The following is a description of a gene set: Human Gene Set: GSE15215_CD2_POS_VS_NEG_PDC_UP Plasmacytoid dendritic cells (pDCs) are key regulators of anti-viral immunity. They rapidly secrete IFN-alpha and cross-present viral antigens thereby launching adaptive immunity. Here we show that activated human pDCs inhibit replication of cancer cells, and kill them in a contact dependent fashion. Expression of CD2 distinguishes two pDC subsets with distinct phenotype and function. Both subsets secrete IFN-alpha and express Granzyme B and TRAIL. CD2high pDCs uniquely express lysozyme and can be found in tonsils and in tumors. Both subsets launch recall T cell response. However, CD2high pDCs secrete higher levels of IL12 p40, express higher levels of co-stimulatory molecule CD80 and are more efficient in triggering proliferation of naïve allogeneic T cells. Thus, human blood pDCs are composed of subsets with specific phenotype and functions. studied in species Homo sapiens Genes up-regulated in comparison of CD2+ plasmacytoid dendritic cells (DC) versus CD2- cells. from publication Matsui T, Connolly JE, Michnevitz M, Chaussabel D, Yu CI, Glaser C, Tindle S, Pypaert M, Freitas H, Piqueras B, Banchereau J, Palucka AK (PMID 19454677), and this is the list of marker genes: MEGF9, FGR, MARCKS, HSPH1, MYL3, RGCC, LPIN2, BCL2, SAMHD1, CDON, INSR, MROH7, ZNF142, RNF19B, ZNF492, SLC39A4, TTLL12, G6PC2, ARSA (NCBI Gene Id 410), DPEP3, VWF, BDKRB1, ZNF444, PRKCZ, MMP14, LAGE3P1, CD163, GAK, VSX1, CD1E (NCBI Gene Id 913), CHST7, ZNF692, DNAAF8, ORAI3, KRT24, COL8A2, MKNK2, RYK, CACTIN, NT5DC2, CLDN11, CCNJL, STAT5A, AGO3, ENG, MAP2K5, PIP4K2B, FAM120A, ASPA, WDR91, TRPV5, WRAP53, CLCN1 (chloride voltage-gated channel 1), SLC35E1, MTAP, ACTN4, TYMP, ENTPD2, HEYL, ISOC1, SEC14L4, PTGS1, DENND2A, BZW2 (basic leucine zipper and W2 domains 2), CIC, NPTX1, ZNF574, GYPC, NGB, SRBD1 (S1 RNA binding domain 1), ENTPD1, EDIL3, MED25, JUND, RAD54B, PFKFB4, SIDT2, NDST1, PAX3, UBN1, KRR1, TAF1C, ACE, TCOF1, SP1, C1orf21, MCOLN1 (NCBI Gene Id 57192), ARHGAP10, SIGLEC6, ZDHHC18, SCNN1G, PLXNA1, S100A9, VIPR1, SHPK, ID3, REST, CTSH, PPARD, ITSN1, MAST2, H2AX, HCFC1, FHOD1, CDC20 (NCBI Gene Id 991), CKB (NCBI Gene Id 96634), KLF9 (NCBI Gene Id 687), SMOX, FCGRT, MLXIPL, PPP5C, HAAO, GFRA3, GJC2, CMKLR1, THAP3, OAZ3, YIPF2, PGAM2, PPT1, SLC34A1, PKD2L2, PLEKHO2, OCLN, INPP5A, AGRN, GLYAT, CBX6, PCDHA9, SPATA2L, HYMAI, TCF20, NR2F6, SETDB1 (SET domain bifurcated histone lysine methyltransferase 1), CYP1A1, CLDN16, KHSRP, PBLD, CAV2, SLC6A2, NUP43, ARVCF, CUBN, ZNF571, MAP4, CSH1, NLRP1, RPRD2, COL7A1, CIDEA (cell death inducing DFFA like effector a), TLN2, KCNA1, INPP5B, ABCB4, YIF1A, SLC44A4, CLASRP, HIVEP3, GPR157, FZD1, WARS1 (tryptophanyl-tRNA synthetase 1), S100A1, KLF15, WASL, NPRL3, POR, OLA1, SNAP25, FTCD, CDC42EP1, CIDEC, SPIN1, GNRH2, MLX, PDE4A, MTNR1B, PTBP3, ENTREP1, PAX9, ATF3, TCF7, LGI2, GNAT1, SNORA21, GCKR, STK11, TRIB3, XYLT1, IGFBP6, CCNT1, HPCAL4, CTH, CEACAM21, KCNK15-AS1, CDC42EP2